The following is a description of a gene set: Human Gene Set: GOBP_POSITIVE_REGULATION_OF_CYTOKINE_PRODUCTION_INVOLVED_IN_IMMUNE_RESPONSE Any process that activates or increases the frequency, rate, or extent of cytokine production that contributes to an immune response. species: Homo sapiens, and this is the list of marker genes: CD81, PYCARD, ARID5A, SIRT1, SEMA7A, IL4, DDX1, TNFSF4, MAP3K7, TICAM1, TBX21, PANX1, CD36, HLA-E, RAET1G, IL18, HLA-F, SLC7A5, DDX21, PLCG2, HK1, FFAR2, DHX36, F2RL1, SYK, CD7, CLEC7A (NCBI Gene Id 64581), HTR2A, INAVA, RSAD2, PRKCZ, IL1B, RIGI, MALT1, MIF, CD160, DEFB131A, NLRP3, CAMK4, NOD1, MAPKAPK2, FZD5, IL1R1, XCL1, WNT5A, TLR3, HLA-A, IL6 (NCBI Gene Id 3569), KIR2DL4, TRIM6, TLR7, FFAR3, FCER1G, IL21, TLR4, BCL10, SLAMF1, RTN4, GATA3, GPRC5B, B2M (NCBI Gene Id 567), HLA-G, KIT (KIT proto-oncogene, receptor tyrosine kinase), CLNK, SPON2, MYD88, MAVS (mitochondrial antiviral signaling protein), IL18R1, DENND1B, CD55, NR4A3, CD74, LILRB1, SASH3, P2RX7, SPHK2, SECTM1, NOD2, LACC1, RIPK2, TRAF6, TNFRSF14, CARD9, LAPTM5 (lysosomal protein transmembrane 5), CD226, IRF5 (NCBI Gene Id 84729), SCIMP, TRAF2 (NCBI Gene Id 7186)